The following is a description of a gene set: Human Gene Set: GOMF_EUKARYOTIC_INITIATION_FACTOR_4E_BINDING Binding to eukaryotic initiation factor 4E, a polypeptide factor involved in the initiation of ribosome-mediated translation. studied in species Homo sapiens, and this is the list of marker genes: EIF4G1, HHEX, DDX3X, EIF4EBP2, C8orf88 (NCBI Gene Id 100127983), LARP1, EIF4EBP3, OTX2, ANGEL1, EIF4EBP1